The following is a description of a gene set: Human Gene Set: WP_SPHINGOLIPID_METABOLISM_OVERVIEW Sphingolipid metabolism overview studied in species Homo sapiens, and this is the list of marker genes: SMPD1, SPTLC1, SPHK1, CERS4 (NCBI Gene Id 79603), DEGS2, SGPP1, SGPL1, CERS3, SGPP2, SPHK2, KDSR, CERS2 (NCBI Gene Id 63903), PLPP3, GBA1 (NCBI Gene Id 82008), UGT8, CERS6, SGMS1, SPTLC2, DEGS1, ASAH1, PLPP2, GBA2, PLPP1, UGCG, CERS1, CERK, SGMS2